Given this list of marker genes ABCC1, MMUT, MTRR, TCN2, MTR, MMACHC, LRP2, MMAB, LDLRAP1, PRSS1, MMAA, PRSS3, CUBN, AMN, CD320, ABCD4, CBLIF (NCBI Gene Id 2694), CTRB2, MMADHC, TCN1, LMBRD1, CTRB1, here is a description of the gene set: Cobalamin (Cbl, vitamin B12) transport and metabolism Human Gene Set: REACTOME_COBALAMIN_CBL_VITAMIN_B12_TRANSPORT_AND_METABOLISM studied in species Homo sapiens